The following is a description of a gene set: Human Gene Set: BDP1_TARGET_GENES studied in species Homo sapiens from publication Yevshin I, Sharipov R, Kolmykov S, Kondrakhin Y, Kolpakov F (PMID 30445619), and this is the list of marker genes: PRR14L, TAF1D, B4GAT1, TMEM43, PXDN, ZNF578, LINC02473, LINC00322, RFX2, KRT7, RAF1, INPPL1, ZNF402P, SLEAR, LINC01980, AKAP10, PTPRVP (protein tyrosine phosphatase receptor type V, pseudogene), SOS1, TP73, SMARCAL1, PRPF31, ABHD16A, RPL38P1, ZFP64, ENSG00000224272, ZDHHC16, HNRNPA1P3, TBC1D1, RPS26P41, GMNN, FCRL6, ANKRD11 (ankyrin repeat domain containing 11), EFCAB10-AS1, MGRN1, OR4C10P, CPT2 (carnitine palmitoyltransferase 2), SMC4, ABLIM1, ZNF569, LINC02136, TNS2-AS1, AJUBA-DT, LINC02739, DVL2, SLC47A2, PDE8B, FZD4, MAST2, NFASC, MED16, RN7SKP178, HMBOX1, PKD1L1-AS1, GRAP2, IMPDH1, RN7SL459P, MIS12, MBD6, TGIF1, MRTFA, LRRC37A9P, CFAP418, TRO, THAP4, DBIP1, ZNHIT3, EIF4A1, PRKCZ, ENSG00000272668, RNA5SP221, RPS2, HDAC9, DNM2, RNU1-30P, PAXBP1, SLC38A5, CALY, ZNF418, TSHZ3, PTCSC3, MLST8, GRSF1, HSP90AB1, SLC25A6P6, GUCY2D, CHD1L, TSNAXIP1 (NCBI Gene Id 55815), RBM8A, CROCC, ACTE1P, FLI1, DTX4, CCT8, PRKAR1B, MIR4787, TPRG1, EIF2B3, TUG1, RPS5, ARNILA, RNF8, ID2-AS1, LRRC41, PPP1R3E, HCG14, TCOF1, POLG-DT, CLUHP3 (clustered mitochondria homolog pseudogene 3), NBR1, ANKRD49, LINC02709, DNAJB12, CERCAM, ANO7L1, OR4C49P, MRPS35-DT, MIR3908, TMEM11, PEBP4, STAR, ZNF70, PELATON, GAS2, ENSG00000226571, SHFL, LINC02917, GGA3, GAB1, SUN1, TBXAS1, DRC7, LINC00667, KDM8, LTA4H, MDH1, RN7SL783P, BRICD5, ABCA7, TPD52L1 (NCBI Gene Id 7164), TMEM109, ATPAF2, ALG2, PSORS1C1, BPIFB1, ANKRD13C, FLAD1, TIA1, ACOX2, XKR4, RPL17P20, CCDC33, PSD4, TANGO6, ATOSB, ELAPOR1, PXMP2, MRPS27, MVB12A, LACTB (NCBI Gene Id 84943), LASP1, RNU6-2, POLK (DNA polymerase kappa), RBM42, CPM, RCN1, DGKA, NT5DC4, SF3A1, MICB, ZNF532, BRD3OS, TLN2, RBMX2P4, TPM3P4, UQCC3, SOX6, LINC01615, RN7SL794P, CNTNAP1, PITPNM2, TEN1, VN1R67P, DCAF10, PABPC1, YWHABP1, H2AZP6, DCTN6-DT, FUNDC1, BATF2, NOS3, PHKA2, DNHD1, USP54, FAXC, SNX29, LINC03126, LPAR6, ZBED3, GMDS, MIR4266, NCOA6, SMARCC2, RAD1P1, THRA, SRRM2 (serine/arginine repetitive matrix 2), ANG, ANAPC2, ADGRF4, ADGRL1, DOCK3, TEN1-CDK3, ARL5C, TMPRSS6, LINC00029, ENSG00000268129, RASAL2, RPL23AP46, NMNAT2, RADX, KRT18, KRAS, PLCE1-AS2, MTND3P1, KLHL34, MRPL1, RNA5SP440, PHF21A, CTNNA2, LTBP3, ADGRE5, PPP4R1, HJV, SNHG14, CAD (NCBI Gene Id 790, carbamoyl-phosphate synthetase 2, aspartate transcarbamylase, and dihydroorotase), STX1A, SIPA1L1, PARP10, CEP131, ADCY3, HMGN2, RN7SK, IQCK, OGFOD3, SNX24, TRBV24-1, MIR4762 (microRNA 4762), BIK, ITGB5, PDCD7, SHF, CCN5, B4GALT7, FAF2, LIF-AS1, EXTL1, GALNS, CRYZ, NCOA7 (NCBI Gene Id 135112), TARS3, FRY, SNRPB2, SCLY, PDE6B, DHX57, HSPA5-DT, OR1E3, DIP2C, IMPDH2, ENSG00000260862, LARP4P, VAMP4, LINC02848, MYORG, PACSIN3, ERCC1, HTR1A, SNORD96A, TCF7L2, CHD3, SKOR1, ATG5, SYNJ2BP-COX16, MPRIP, NENFP1, RAB26, GSE1, PTCD1, SLC12A8, TFR2, ERBB2, ABCB9, SMU1, MIR154, JMJD1C-AS1, IQCN, SACM1L, LTBR, H3C9P, LRRTM3, SCNM1, LRTM2, MACROD1, PCLO (NCBI Gene Id 56630), PMAIP1, PRANCR, DCTN5, ZMYM3, ENSG00000269172, SMARCD2, MARF1, CYBRD1, SPARC, CEP135, OGG1, RSRC1, DIS3L2, MYOM2, ZFYVE21 (NCBI Gene Id 79038), ZDHHC14, SNHG9, LINC01055, RNU6-7, CLIP2, OR9N1P, A4GALT, TH2LCRR, PIGG, KBTBD6-DT, DMKN, SEMA4G, STAB1, LINC01013, PLPP3, FBXL17, ENSG00000262966, PAMR1, RANBP17, GPR155, FOXRED1, CRHBP, IGHV5-51, C1orf56, LAP3, ZNF225, TMEM259, KLF6, BCAT1, SATB2, TMEM11-DT, FYB2, MKS1, LINC00240, SNORD115-32, SLC1A4, ZNF790, VARS2, ATRNL1, FBXL13, INTS1, PKD1, PRMT5-DT, RNA5SP46, USP30, CBX7, RIN3, LRRC25, DCUN1D2, FOSL2 (FOS like 2, AP-1 transcription factor subunit), TCF25, CFAP99, DHFRP1, TXNIP, PCLAF, COL27A1, LYPD1, DKK3, SNORA78, MIR221, HGD, USP53, RN7SL531P, GHET1, PRDM7, COX14, SLC25A14, ZAP70, ERVV-1, ENSG00000231863, VPS72 (vacuolar protein sorting 72 homolog), LRRC32, TNK2-AS1, WARS1, CECR2, LINC01868, UBR1, CGB2, HRH1, HEATR5A-DT, NPEPL1, PEX3, DDX52, MYO3A, CDHR2 (cadherin related family member 2), DPH1, ZNF707, LINC00200, GABPB2, CSRP1-AS1, TP53TG3GP, TRAPPC14, RAB43, PHF19, PON3, FLNC, TAOK3, CIT, FAAHP1, EIF3K, WBP4, FTSJ3 (NCBI Gene Id 54803), COL1A1, RNY4, NT5C, PTGER4, EDC4, SLC6A17-AS1, PNPLA1, RNA5SP531, SEPTIN8, ARHGAP45, MAP9-AS1, GLYCTK-AS1, VPS11, FAM177A1, MAP1LC3BP1, CDK5RAP2, SYNJ2BP, NODAL, FANCD2, ZDHHC17, ENSG00000238142, IFRD2, SUMO2P18, CHD1, PPM1F, GRAMD4, HIGD1AP3, LRRC77P, FMC1-LUC7L2, OR7E22P, CCDC51, LIMD1-AS1, LINGO1, CAMK2G, MYG1, RBM43P1, AKAP8L, ANXA9, AGTR1, ADAD2, FEM1A, SPON1-AS1, LENEP, ERBB3, HMGN4, POLR1B, LINC00317, PLA2G2C, RNU6ATAC41P, LIN28A, MCAM, CHRNA2, TMEM132B, AP5S1 (NCBI Gene Id 55317), BACH1-AS1, VTRNA1-1, FBXO38-DT, TGM4, P3R3URF-PIK3R3, CFAP61, ATG12, SLC4A8, LINC02803, HCG20, ADGRV1, DPF2, OR2L8, RPS10, FMC1, TPTE2P1, LINC02005, MAP1LC3B, RERGL, COTL1, METTL25, RNU6-9, SLC9A2 (solute carrier family 9 member A2), BCAR3, RUNX1, POC1B, RIF1, MIF, VGLL4, CLSTN3, RN7SL752P, BBC3, ENSG00000267248, H4C8, DST, TRPV3, ELF1, DNAJC6, SH3KBP1, ZDHHC3, RHOBTB3 (Rho related BTB domain containing 3, NCBI Gene Id 22836), MIR365BHG, KCTD10, GRB10, SFTA2, STRN4, NDUFB10, COA7, CD226, PRKCA, TRMU, NUP133-DT, DIP2A, LINC02428, RNF207, FAM131C, LINC02609, CDCA3, SRL, ZNF568, RNU6-528P, FTLP6, CASC8, IGLV8-61, CD81, TRPM3 (NCBI Gene Id 80036), CSMD1, ZNF213-AS1, CLNK, PER2, MIR548W, WRAP53, DIAPH1, FBXO38, TOP1MT, RN7SL442P, LAD1, PLEKHG2, MYO1F, ZNF668 (zinc finger protein 668), ENGASE, ING4, LRRFIP2, BOD1, ASB3, TRBV22OR9-2, TANAR, TMEM63C, ARHGAP22, ENSG00000236935, DDR1, ATP5PO, AP1G2, TUBA1A, CDKL4, GSAP, CD83P1, WDR25, BARX1, USP49, BTK, C12orf54, GNG3, GRHL1, EPS8L3, MYLK3, SLA, RNF216-IT1, RPL31P38, TMEM25, ST7L (suppression of tumorigenicity 7 like), SUMO2P6, PPY2P, TTYH1, FAN1, PPFIA3, PHLDB2, FEM1B, PODNL1, PTDSS2, RASSF10, PSME2, SECISBP2, C1orf159, SNX1, SEMA6C, RPS29P5, RPPH1, SMAD4, TCEA1, UBE2G2, CES5A, SSX6P, RPL18A, TNFRSF25, SNORD48, RNA5SP439, ATP2B2, TAF3, TTC36-AS1, HMGXB4, MPHOSPH8 (M-phase phosphoprotein 8), H1-8, MAN2B2, GLUL, FAIM2, PACC1, ARRDC3, MTCO3P12, WDR12, CACNA1A, GLYCTK, ENSG00000231083, SPACA6, AP3S1, MRPL12, LINC02236 (NCBI Gene Id 109729133), MIR99B, RPS27P30, XIST, CYP1B1, CACNA1D, ZNF69, RPUSD2, NAV2, MRPS15, EHMT1, BRD9, BCL2L13, ACTB, PTK7, ENSG00000232900, TRIM7-AS2, SDCBP, SEM1, UBE3D, ALOXE3, IQGAP2, PSMB3, FASN, RDH8, LINC02540, RAB25, LCOR, LDLR, BSCL2 (NCBI Gene Id 84753), SLC46A1, ANK3, DGCR2, PTPRZ1, GAPDHP39 (glyceraldehyde 3 phosphate dehydrogenase pseudogene 39), RBM5, MAPKAPK5, GINS3, CSTF1, PDE9A, XXYLT1, ASAH1, ADCY5, EPHA1, LINC03108, BDKRB1, FLII, SIRPG, AGFG2, NISCH, KAT14, NRBP1, COPB2, MAN2A1, UBE2I, MDM2 (NCBI Gene Id 84825), CERT1, TARS2, CYB561A3, OGFOD2 (2-oxoglutarate and iron dependent oxygenase domain containing 2), POLM, COMMD9 (NCBI Gene Id 399879), ZNF587B, HGS (hepatocyte growth factor-regulated tyrosine kinase substrate), KDM2B, MALAT1, PUS10, CAPN8, COPZ2, STAT2, DENND2C, AHDC1, MROH8, SMG6, LINC03060, IKZF4, SNHG32, TANGO2, AUP1, SORCS3, DNAJC4, VOPP1, RNU6-992P, RACK1, LAMA5, MIR222, NDUFB3, EIF4G1, STARD3, FBXW5, OR2S1P, STPG4, CNBD2, TMEM94, LYZL6 (lysozyme like 6), RNF220, HNF4G, SESTD1, PRPF8, ENSG00000229727, LDC1P, LINC01214, LIFR, PARP2 (NCBI Gene Id 10038), MAP3K19, BRK1P1, YARS1, PLCE1, CARD14, RNU6-244P, SHBG, ZEB2, NT5C2, PDILT, PLEKHG3, OR7E47P, WASF4P, CDA, OSBPL3, HSD17B7, ARID3A, EIF3E, DCTN6, PRSS35, LINC02024, SRSF5, INTS2, TRBV8-2, LMNA, LINC01586, ZNF474, COG2, GZF1, CORIN, H3P46 (H3 histone pseudogene 46), FBXO44, VASP, LINC00352, CA3 (NCBI Gene Id 761), YJEFN3 (YjeF N-terminal domain containing 3), AFAP1-AS1, CWC15, VTRNA1-3, MFSD1, SPRR4, TYW1, COMMD1, KCNB1, VTRNA2-1, S100PBP (NCBI Gene Id 64766), POLE, LATS2-AS1, ATP2A2 (ATPase sarcoplasmic/endoplasmic reticulum Ca2+ transporting 2), CDC42SE1, MYOF (NCBI Gene Id 26509), ADAM17, INSYN2B, MBTPS1, RNF145, PCP4L1, GAPDHP30, NDUFA3, STX1B, ARHGEF7, RNA5SP67, NXF3, CD79B, MED11, WDPCP (WD repeat containing planar cell polarity effector), SLC6A2, RFC4, ZC3H12A, PUF60, ETNK2, KRT19, NDUFS1, RN7SKP189, AP3D1, RHBDD1, FGFR3P3, ATP6V0D1, SIPA1L2, CXXC1, SNORD21, GABRA4, FBRS, COL17A1, VOPP1-DT, P3R3URF, GREB1, SMPDL3A, TG, TPM2, PSMC5, RNA5SP134, NXNL2, ZFYVE28, CYP4F3, MARK2, RANBP10, MIR892C, POMGNT1, EZR-AS1, PPP1CA, NAP1L4, RNY1, ENSG00000277182, IAH1, NR5A1, FOXO1, FNDC3B, S100A5, H1-7, CA10, TRAJ57, PIP5K1P2, CALML4, RBCK1, MIR6500, PPP1R21-DT, TBC1D2, LRP3, ENSG00000254337, NDUFS2, ACSL6, FRMD3, NRP1, SNRPA, PPEF1, CPSF4, CACNA2D1, RBSN, MIDEAS, TBC1D14, HSF1, GABARAPL1, LOXL1-AS1, RNU6-1102P, CHFR, COX19, CRYBG3 (crystallin beta-gamma domain containing 3), DNAJC7, SNORA9, RNPEPL1, GRK2, OSTCP2, MIR4521, DYM, TFPT, LINC01556, NGEF, FNIP2, RNU6-855P, PSME2P6 (proteasome activator subunit 2 pseudogene 6), CYP11A1, RUNX2, AJUBA, GSTM5, PEX16, GPBAR1, LINC00608, AEBP1, ID1, FGD4, MAILR, LINC00907, WIZ, EPIST, ERLEC1, HGF, CNOT1, HEATR5A, KDM4D, PGAM2, GLRX, STEAP2-AS1, NECAP1, RNF227, CGB1, SETDB2, H3P2, PEAR1, DNAJB6P1, MYCBPAP, ZHX3, DOT1L, PTPN1, ENSG00000276170, PRR13P5, TMA7, R3HDM4, RIPOR3, STX17, MFAP2, ENSG00000206913 (NCBI Gene Id 124902824), P2RY12, COG4, TRIM41, MRPS33, VIPR1 (NCBI Gene Id 9357), MIR190B, SOWAHB, HK3, HPS4, SVIL2P, EXD2, HSPA6, XRCC5, OVCH2, COX6CP7, TOX2, UBAP2L, RHOJ, DGCR8, ZFP36L1, SEC22B, MIR499B, NR2F2-AS1, NR1H3 (NCBI Gene Id 113429), CUZD1, MED24, GUCY2GP, ENSG00000259200, CATSPER2P1, NIBAN3, TAGLN, RN7SL2, LAMA5-AS1, PPP3CA, SNX18, SEC61B, MRPS23, EFEMP2, C2orf42, MAU2, MIR6854, GNE, TMEM167B, HRG-AS1, CD151, TCHP, TYW3, ENSG00000212378, METTL26, CRNKL1, MRPS35, RNA5SP145, BMF, ILVBL-AS1, S100A13, CABIN1, DPP3P2, CEP192, CLNS1A, SLC38A8, MRPS25, FTH1P6, ZFP14, NFIC, PCED1B, ILF2 (NCBI Gene Id 3608), PTPN9, RIN1, CCDC157, CBY2, MIR616, POMT1, GSTM3P2 (NCBI Gene Id 100421057), RAB11A, CARF, RASAL2-AS1, SPACA6-AS1, FJX1, LGALS3BP, RPA2, MTRR, STK25, KMT2A, SNORD115-26, CPT1B, DPP9, ZNF292, RARA, TNS2, HTRA2, DEF8, SIN3A, PPL, APRT (adenine phosphoribosyltransferase), C10orf90, HSBP1, RPS29, MISP3, RPL22, PEX13, TSSK1A, HBS1L, ANKDD1A, CTDSP2, IL2RA, KRTAP4-11, ZCCHC2, BIVM, RBM4, XRCC3, AURKA, FBXO15, HLFP1, MIR4421, IL11RA, TRIM15, ENSG00000202498, RAPH1, ICAM5, PDIA2, EHD4-AS1, AGBL5, SLC27A4, KNL1, LINC02181, TCEA2, RTKN2, ZBTB38, PLA2G4F, TCP11L2, CEP72, MICAL2, NSD2, AXDND1, VWA7, LBX1, PLOD3, ATG101, ZNF433-AS1, MGA (NCBI Gene Id 84130), EDEM3, ST3GAL4, CPPED1, ATPAF1 (ATP synthase mitochondrial F1 complex assembly factor 1), ENSG00000254607, TRAJ45, NDFIP1, BRD4, LRRK1, DNAAF5, ENSG00000275527, TRGJ2, SLC41A1, INPP5F, ELL3, GCAT, GJC2, PGR, AKT2, ZNF804A, SLC66A2, SLC12A5, YPEL3, IDE, GRB2, RNASE4, SLCO3A1, CAMKV, TGFBI, PPP6R3, SLC16A7, RAB5IF, WDR37 (NCBI Gene Id 22884), KLC4, MCM2, SNX8, ZMYND19, SLC2A14, MITF, TRAPPC2, DNAH11, CORO6, EHBP1-AS1, ATP6V1E1, LINC01500, PIR, KRT6A, HSP90B1, PLXDC1, IGFBP2, HRCT1, APC2, EIF4A3, ARAP1, PDE3B, EPS8, ARHGAP44, HOXA7, CTNNBL1, RUFY1-AS1, SEMA5B, ANKRD29, MIR4515, EPB41L3, GRN, RNA5SP206, ACTR3-AS1, TNFSF15, DCAF15, ACOX1, AATF, LMAN1L, RN7SL341P, GAPVD1 (GTPase activating protein and VPS9 domains 1), CDK12, MPHOSPH9, ENSG00000258538, FAM174B, ALMS1P1, SOCS5P1, LINC01623, TIPARP, MIR181D, NNMT, CYP4F8, SPINK2, RNU6ATAC19P, SHMT2, SAFB2, PDE4B, ZNF70P1, MACF1, SYNE1, HDGF, QTRT2, MAD2L1BP, ADAM33, B3GALT4, WNT5A, TMEM145 (NCBI Gene Id 284339), S100A1, ECE1 (endothelin converting enzyme 1), HIPK2, PET117, GPT2, PAOX, IL5RA, VPS35L, MTND2P40, POGLUT2, POLR1F, CASC22, CD6, RPS14P7, PLAU, DDX24, MSL1, LINC01435, DMTN, TRAPPC2L, PRMT5 (protein arginine methyltransferase 5), LINC00598, SERPINA12, LYSMD1, WRNIP1, VPS13D, TPD52, FEN1, HECW1, RNU6ATAC, CCR1, DDX19A, TRIM60P19, LINC02176, MIR4299, RAB37, CCDC144NL-AS1, ARMC2, RPH3A, ARPP19, SNAP25, LRRC17, ZNF56P, CWC25, NXPH1, ZAR1L, CLIC1P1, COLGALT1 (NCBI Gene Id 79709), FDX1P2, DTNB, LIG1, OR5AU1, RBM24, CEP162, FRMPD2, PPIAP3, RN7SL42P, RPS10-NUDT3, HDC, FBXO31, LINC00635, CELF3, ZNF626, ZNF732, GPR132, PPP2CA, GSTA4, PSMA1, GCN1, MIR3929, SNRPGP5, GYPC, SNORD115-7, MORN2, MYDGF, GOLIM4, KCNK6, S100Z, COMTD1, PPP1R12C, EXOC2, RTN4R, DUSP29, DECR2, NF1, ARL10, POLR3E, ODF1, CARD8-AS1, LINC00951, STAU1, WIPI1, LINC02684, NDUFS7, MIR4701, MCRIP2, GTF3A, RN7SL40P, DCAF17, RAC1, TOMM7, ADGRD1, GLB1, ZNF76, MYNN, CHD4, BBLNP2, RHOA-IT1, AGBL5-AS1, RNASEH2B-AS1, BCYRN1, RPL32P20, CP, TNF, SEL1L2, PSMD3, C8G, TPM4, OR5G5P, DPF1, HDAC7 (histone deacetylase 7), IFT80, MECOM-AS1, P3H3, EP400 (E1A binding protein p400), TEX2, SLC25A3, PAXIP1, RAC3, CTDSPL, SAMD12, TGFB3, RALB, TAGLN3, DCAF4, GRAMD2A, INPP4B, NIPA2, ERCC6L, AIRIM, VPS28, TRAF2, PER3, ALAD, SAR1B, TSR2, WWP2, TP53BP1, TENM4, NR4A1, MIR4274, MIR9-2HG, DPP8, PRNP, ZNF839, RN7SL1, QSER1, LINC02453, RMND5A, ENSG00000228771, SORL1, TUBA8, PALB2, EEF1GP7, LINC02284, COQ8A, DDX10, LINC02132, BCO2, LINC01950, WSB2, RBM33, ZNF432, RPL36AP40, HMGN1P24, LRPPRC, MTSS1, HEXD, LINC01962, OR52K1, PLD2, CPHL1P, RMRP, WBP2, RN7SKP271, COL16A1, ESR2, FHL1, MIR6069, SRPRA, SPG21, DUOXA1, ANTKMT, CCDC184, ARHGEF17, SELL, GHR, ZDHHC1, LLGL2, MATCAP1, IRF8, RN7SL868P, U2SURP, PANK4 (pantothenate kinase 4 (inactive)), ZNF320, PTGR3, CCDC174, KYAT1, C2CD2L, B4GAT1-DT, MEN1, CNTN2, CCDC59, ZNF225-AS1, ADCY4, CRLS1, COL7A1, KRTAP16-1, DMBX1 (diencephalon/mesencephalon homeobox 1), ZBED3-AS1, HMSD, BBS9, BEX4, JUNB, CYTH1, RABAC1, LINC00663, MIR6745 (microRNA 6745), ENOSF1, VTRNA1-2 (vault RNA 1-2), ANO2, ITGAE, RUFY1 (NCBI Gene Id 80230), CAPRIN1, IL17RE, LINC02723, RNF11P2, HNRNPA1L3, GREB1L, ITPA, VAV1, CTC1, KLHDC8B, SMIM19, CLBA1, NIPAL1, CCDC107, NOL7, ENSG00000201733, SRRM2-AS1, ALDOA, ABHD12, P2RY2, RNY3, ANXA11, SEMA4A (semaphorin 4A), ESD, AKAP9, NRP2, MYL11, RNU6-8, SPMIP4, CXXC5, MPP3, ACO2, RNASE11, RNU6-1, CRIPTO3, AMBRA1, SERF2, MXD1, ITPR1, POLG, MAN2A1-DT, RECQL5, SPTLC1, NOTO, PDZD4, NOD2, ARHGAP23, ZNF853, SRPK2